Given this list of marker genes MPST, ETHE1, SP1, CBS, ENSG00000274276, MIR21, CTH, here is a description of the gene set: The chemical reactions and pathways involving hydrogen sulfide, H2S. Human Gene Set: GOBP_HYDROGEN_SULFIDE_METABOLIC_PROCESS species: Homo sapiens